The following is a description of a gene set: part of: Metabolism of proteins The family of Insulin like Growth Factor Binding Proteins (IGFBPs) share 50% amino acid identity with conserved N terminal and C terminal regions responsible for binding Insulin like Growth Factors I and II (IGF I and IGF II). Most circulating IGFs are in complexes with IGFBPs, which are believed to increase the residence of IGFs in the body, modulate availability of IGFs to target receptors for IGFs, reduce insulin like effects of IGFs, and act as signaling molecules independently of IGFs. About 75% of circulating IGFs are in 1500 220 KDa complexes with IGFBP3 and ALS. Such complexes are too large to pass the endothelial barrier. The remaining 20 25% of IGFs are bound to other IGFBPs in 40 50 KDa complexes. IGFs are released from IGF:IGFBP complexes by proteolysis of the IGFBP. IGFs become active after release, however IGFs may also have activity when still bound to some IGFBPs. IGFBP1 is enriched in amniotic fluid and is produced in the liver under control of insulin (insulin suppresses production). IGFBP1 binding stimulates IGF function. It is unknown which if any protease degrades IGFBP1. IGFBP2 is enriched in cerebrospinal fluid; its binding inhibits IGF function. IGFBP2 is not significantly degraded in circulation. IGFB3, which binds most IGF in the body is enriched in follicular fluid and found in many other tissues. IGFBP 3 may be cleaved by plasmin, thrombin, Prostate specific Antigen (PSA, KLK3), Matrix Metalloprotease-1 (MMP1), and Matrix Metalloprotease-2 (MMP2). IGFBP3 also binds extracellular matrix and binding lowers its affinity for IGFs. IGFBP3 binding stimulates the effects of IGFs. IGFBP4 acts to inhibit IGF function and is cleaved by Pregnancy associated Plasma Protein A (PAPPA) to release IGF. IGFBP5 is enriched in bone matrix; its binding stimulates IGF function. IGFBP5 is cleaved by Pregnancy Associated Plasma Protein A2 (PAPPA2), ADAM9, complement C1s from smooth muscle, and thrombin. Only the cleavage site for PAPPA2 is known. IGFBP6 is enriched in cerebrospinal fluid. It is unknown which if any protease degrades IGFBP6. species: Homo sapiens Reactome Pathway: Regulation of Insulin-like Growth Factor (IGF) transport and uptake by Insulin-like Growth Factor Binding Proteins (IGFBPs), and this is the list of marker genes: C4A, GOLM1, FBN1, TF, AHSG, IGFBP6, SERPINA1, AFP, CHRDL1, SERPINC1, IGF1, PRKCSH, FSTL3, APLP2, SCG2, MMP1, DNAJC3, APOB, IGFBP1, TMEM132A, APP, KNG1, SERPINA10, LGALS1, LAMC1, PNPLA2, PCSK9, DMP1, CST3, NUCB1, FGG, FSTL1, LAMB2, CDH2, MEPE, F2, PAPPA2, STC2, MBTPS1, IL6, SCG3, MFGE8, MATN3, AMELX, CHGB, CCN1, CSF1, CTSG, HRC, ITIH2, HSP90B1, AMBN, BMP15, SPARCL1, KLK2, CKAP4, PRSS23, SPP2, AMTN, NOTUM, P4HB, IGFBP2, APOE, VGF, WFS1, ANO8, KTN1, CP, TIMP1, PAPPA, IGFBP5, MXRA8, FGF23, EVA1A, BPIFB2, C3, VCAN, VWA1, MELTF, IGFBP4, RCN1, TNC, F5, SHISA5, MGAT4A, GPC3, MEN1, SDC2, KLK13, FGA, SPP1, FUCA2, QSOX1, APOL1 (NCBI Gene Id 8542), APOA5, MIA3, IGFBP7, LAMB1, APOA2, TGOLN2, CALU, KLK3, ALB, IGF2 (NCBI Gene Id 492304), MSLN, PLG, IGFBP3, PDIA6, LTBP1, PROC, PENK, FAM20C (FAM20C golgi associated secretory pathway kinase), SERPIND1, FN1, IGFALS, APOA1, KLK1, ENAM, GZMH, BMP4, GAS6, MMP2, ADAM10, FAM20A